Given this list of marker genes D7Ertd443e, Birc5, Cdc20, Clspn, Chek1, Rad9a, Tex14, Mus81, Klhl22, Cdc14b, Zw10, Cenpe, Trrap, Chek2, Nuf2, Mad2l1, Bub1b, Brcc3dc, Wac, Nae1, Rpl24, Dgkz, Hus1b, Plk3, Mbtps2, Cdkn1a, Zfp830, Vps4a, Eme2, Fancd2, Babam1, Map3k20, Atf2, Mbtps1, Rad50 (RAD50 double strand break repair protein), Trim39, Rad9b, Ints3, Usp44, Foxn3, Brca1, Ccng1, Ccnd1, Zfp207, Stil, Spc24, Nek11, Prap1, Trex1 (NCBI Gene Id 22040), Taok3, Haspin, Fzr1, Xpc, Cdca8, Trip13, Bub1, Incenp, Msh2, Rbbp8, Cdc6, Cdk5rap2, Eme1, Tpr, Ccnb1-ps, Cdk5rap3, Mtbp, Orc1, Aurkb, Uimc1, Donson, Mad1l1, Cdk1 (NCBI Gene Id 12534), Mad2l1bp, Zwilch, Chfr, Etaa1, Taok1, Ppp1r10, Brsk1, Brcc3, Mre11a, Cep192, Khdc3, Nabp2, Nabp1, Bard1, Dync1li1, Trp53 (NCBI Gene Id 22059), Spc25, Inip, Zwint, Stk33 (serine/threonine kinase 33), Mrnip, Ska1, Nop53, Ptprv, Spdl1, Chmp4c, Rint1, Xrcc3, Ccnb1, Gigyf2, Dusp1, Tipin, Prpf4b, Babam2, Anapc15, Prkdc, Rfwd3 (ring finger and WD repeat domain 3), Lcmt1, Foxo4, Rad17, Knl1, Rps27l, Dtl, Atr, Apc, Topbp1, Hus1, Taok2, Pabir1, Gen1, Sde2, Bub3, Ticrr, Abraxas1, Ier3, Zfyve19, Mbd4, Psmg2, Nbn, Syf2, Kntc1, Ska3, Plk1, Creb3l1, Rpa2, Ndc80, Ttk, Arhgap33os, Blm, Rps6, Setmar, Atm, Pcid2 (NCBI Gene Id 234069), Ik, Fbxo31, Anapc15-ps, here is a description of the gene set: Mouse Gene Set: GOBP_MITOTIC_CELL_CYCLE_CHECKPOINT_SIGNALING species: Mus musculus A signaling process that ensures accurate chromosome replication and segregation by preventing progression through a mitotic cell cycle until conditions are suitable for the cell to proceed to the next stage.